Given this list of marker genes Cyp7a1, Slc27a6, Cyp4a30b, Apoc3, Apoa5 (NCBI Gene Id 66113), Cyp4a12a, Cd36, Acaa1a, Scp2, Adipoq, Ucp1 (uncoupling protein 1 (mitochondrial, proton carrier)), Fabp3, Gk, Sorbs1, Me1, Rxrg, Angptl4, Fabp4, Acsl1, Acadl, Acadm, Pck2, Cyp4a32, Ilk, Fabp6, Pparg, Slc27a5, Scd1, Cpt2, Cyp4a29, Acsl4, Cpt1c, Mmp1a, Ppara, Acox3 (NCBI Gene Id 80911), Cyp4a12b, Ppard, Acaa1b, Ubc, Fabp2, Fabp5, Cpt1a, Apoa2 (NCBI Gene Id 11807), Hmgcs2, Pck1, Acsbg2, Ehhadh, Nr1h3, Fabp7 (NCBI Gene Id 12140), Slc27a1, Cyp8b1, Cyp4a31, Rxra (retinoid X receptor alpha), Acox1, Cyp4a14, Acox2, Aqp7, Acsl6, Mmp1b, Olr1, Slc27a4, Scd4 (stearoyl-coenzyme A desaturase 4), Lpl, Scd3, Dbi, Pdpk1, Plin1, Fads2, Apoa1, Cyp27a1, Cpt1b, Gk2, Scd2, Pltp, Acsl3 (NCBI Gene Id 96921), Acsbg1, Cyp4a10, Slc27a2, Fabp1, Acsl5, Rxrb, here is a description of the gene set: Mouse Gene Set: WP_PPAR_SIGNALING_PATHWAY studied in species Mus musculus PPAR signaling pathway